Given this list of marker genes Foxq1, Pou4f2, Hey2, Bhlhe40, Nr2e1, Hic1, Mlx, Klf17 (Kruppel-like transcription factor 17), Bach2, Atf7, Tcf7, Hes5, E2f7, Sox6, Yy1, Gtf2ird1 (general transcription factor II I repeat domain-containing 1), Gm32687, Zgpat, Ctcf, Tbx15, Dach1, Gsc, Purb, Bcl11a, Smad5, Zfp125, Ets2 (NCBI Gene Id 23872), Zfp692, Crem, Zbtb25, Rest, Pparg, Zfp869, Nr2c1, Zbtb16, Aebp1, Zfp219, Mxd4, Creb3l1, Ascl3, Hand1, Zfp1006, Myef2, Zkscan3, Foxg1, Samd11, Zfp750, Stat6, Sp2, Tbx2, Tbx3, Nfatc2, Zbtb39, Zbtb34 (NCBI Gene Id 241311), Tbx6, Vax1, Foxa2, Nr6a1, Hoxb8 (homeobox B8), Bcl6b, Zfp3, Zeb2, Zbtb7a, Insm1, Pax6, Ferd3l, Zfp202, Zfhx3, Cc2d1a, Tfap2a, Vsx2, Trps1, Zfp457, Foxp1, Gfi1, Zbtb20, Ascl5, Bmyc, Tfcp2l1, Satb1, Glis1 (NCBI Gene Id 230587, GLIS family zinc finger 1), Hbp1, Snai2, Nacc2, Esrra, Irx1, Neurog3, Zfp217, Elk3, Foxd3, Nanog, Zfp715, Ppara, Pax4, Vax2, Zfp973, Irx2, Atf3, Zbtb45, Nr2f1, Bhlhe41, Eomes, Rara, Hesx1, Zbtb49, Prop1, Jph2, Zbtb37, Hdgf, Foxs1, Snai3, Nr3c1 (nuclear receptor subfamily 3, group C, member 1), Esx1, Batf3, Hif1a, Zfp746 (NCBI Gene Id 69228), E2f8, Zbtb10, Zfp13 (NCBI Gene Id 240046), Bach1, Foxp2, Zbtb32, Hoxb13, Myc, Mnt, Zbtb5, Lef1, Nfx1, Thap1, Zfp512b, Zeb1, Mnx1, Tfec, Eno1, Nfatc1, Nfe2l3, Ascl1, Insm2, Zbtb14, Gata3, Satb2, Zbtb2, Foxp4, Mypop, Prox1, Cdx2, Nkx6-1, Jun, Skil, Mxi1, Hoxd9, Irx6, Hes6, Hsf1, Zfp263, Prdm1, Tbx18, Max, Spi1, Mafk (NCBI Gene Id 17135), Eno1b, Srebf2, Mxd3, Zfp433, Zbtb1, Zbtb4, Sp3, Mxd1, Mlxipl, Klf12, Trp53, Prdm5, Tgif1, Hdac5, Samd7, Zfp976, Zfp970, Rela, Prrx1, Zbtb26, Gm3604, Hes2, Zbtb46, Zfp382 (zinc finger protein 382), En1, Sp5, Heyl, Twist1, Zbtb7b, Irx3, 5730507C01Rik, Msc, Patz1, Msx1, Zfp175, Foxk2, Pura, Scrt1, Mkx, Zfp1007, Myt1l, Pou6f1, Zfp729a, Zfp131, Hhex, Zfp536, Irf8, Tgif2, Dmbx1, E4f1, Gm45871, Isx, Tcf3, Sox13, Zfp668, Nfil3, Mzf1, Zc3h8, Nkx3-2 (NCBI Gene Id 12020), Cc2d1b, Rorc, Helt, Zbed6, Zfp354c (NCBI Gene Id 319696), Fezf2, Ski, Zfp1005, Zfp958, Foxp3, Zfp950, Zfp418, Ppard, Otp, Lrrfip1, Ovol2, Hes7, Tbx21, Prdm14, Tcfl5, Klf8, Thap11, Jdp2, Hey1, Zfp281, Zfp90, Fezf1, Arx, Zbtb33, Pitx2, Foxo1, Prdm16 (NCBI Gene Id 70673), Gm14399, Etv3, Pou5f1, Ikzf5, Zbtb21, Foxr1, Glis3, Gm14412, Bcl6, Kcnip3, Klf16, Hes3, Nfatc4, Hmx1, Msx2, Zbtb8a, Nr1d2 (nuclear receptor subfamily 1, group D, member 2), Zfp997, Nr1d1, Zbtb24, Deaf1, Gm14443, Hes1, Hinfp, Nfe2l1, Cebpb, Klf3, Shox2, Tcf21, Zfp442, Ovol1, Cux2, Pou4f1, Prdm2, Foxo3, Sox30, Pou3f1, Smad3, Gzf1, Zbtb6, Zbtb12, Zfp239, Foxk1, Tfap2c (transcription factor AP-2, gamma), Nkx6-3, E2f6 (NCBI Gene Id 50496), Nfatc3, Ylpm1, Zfp148, Mynn, Etv6, Nfkb1, Ascl2, Nr2f6, Zfp819, Dlx4 (distal-less homeobox 4), Snai1, Hsf5, Hoxa2 (homeobox A2), here is a description of the gene set: Mouse Gene Set: GOMF_DNA_BINDING_TRANSCRIPTION_REPRESSOR_ACTIVITY species: Mus musculus A DNA-binding transcription factor activity that represses or decreases the transcription of specific gene sets.